Given this list of marker genes AKR7A2, CBR4, AKR1B10, AKR1B1, AKR1C2, SLC34A1, AKR1C1, AKR1A1, AKR1C4, AKR1C3, here is a description of the gene set: species: Homo sapiens The chemical reactions and pathways involving an aminoglycoside antibiotic, any member of a group of broad spectrum antibiotics, of similar toxicity and pharmacology, that contain an aminodeoxysugar, an amino- or guanidino-substituted inositol ring, and one or more residues of other sugars. The group includes streptomycin, neomycin, framycetin, kanamycin, paromomycin, and gentamicin. Human Gene Set: GOBP_AMINOGLYCOSIDE_ANTIBIOTIC_METABOLIC_PROCESS